The following is a description of a gene set: Human Gene Set: MODULE_23 studied in species Homo sapiens Liver genes - metabolism and xenobiotics., and this is the list of marker genes: FZR1, PAX3, HMGCS2, CITED2, CPB2, CYB5A, PLG, ARHGDIG, SCO2, ITIH2, AQP3, SLC13A2, SMAGP, SOD3, CYP2B6, NOVA1, PROC, KCND3, POLD2 (DNA polymerase delta 2, accessory subunit), ECI1, ROR2, PCK2 (NCBI Gene Id 5106), C2, CNKSR1, ODF1, SNCG, ALAS2, CFHR3 (complement factor H related 3), AKR1C3 (aldo-keto reductase family 1 member C3), SLC22A18AS, HCN3, DOK1, MMP11, NFKBIB, AKR7A3, SERPINA4, MTHFR, VGF, SELENOP, TBX19, DPT, PTCH1, CD14, TNFRSF10B, LGMN, CFAP410, GRK1, CYP2A7, HAP1, UBE2L6, IGFBP2 (insulin like growth factor binding protein 2), PLCG2, C6, CLEC10A, APCS, IGF1, SLC7A11, ITIH3, AADAC (NCBI Gene Id 13), LRP1, IGFBP1, MAOA, PCBD1, PHYH, ASGR1, XDH, ARID1A, SFTPC, INHBC, FBP1, CYP4F3, VSIG4, ARSA, C4BPA, MAP2K3 (mitogen-activated protein kinase kinase 3), CHRNB1, ABLIM3, AGPAT2, E2F1, GPX3, AQP5, SPRR2C, ARC, RHBDL1, TIMP3, HPD, CDC42EP1, FGA, SRPX, HTR2A, CYP2C8, CYP2D6, ITIH4 (inter-alpha-trypsin inhibitor heavy chain 4), QSOX1, HGD, FURIN, TCIRG1, PRELID3A (NCBI Gene Id 10650), TRIM16, VAMP5 (NCBI Gene Id 200553), TNFRSF14, APOB, COL18A1, DNASE1L3, GPLD1, NTNG1, ACOX1, DDC, FGR, DAO, CHPF, ALDH1B1, RHOB, AKR1C1, CYP2A6, DOLK, AGXT, ENPP1, MGP, TYR, DKK4, ACOX2 (NCBI Gene Id 8309), GJB1, FLOT1, EFNA2, GYPB, SLC38A10, FN1, VSNL1, HP, ATF5, GATM, CPN2, MEF2C (myocyte enhancer factor 2C), FUCA1, PCYT2 (NCBI Gene Id 5833), DDT, RPS26, MUC1, SORBS2, F2, FGL1, NR0B2, MEN1, RBP1 (retinol binding protein 1), ALDH1L1, STAT2, MTHFS, PEPD, EGFR, BCL2, FETUB, VEGFA, ATP4A, TGFB1, CD3E, IL4R, ERBB3, SYNPO2L, CES1, TBXT, HPR, IKBKG, IFI27, CELSR3, ITGA5 (integrin subunit alpha 5), LCAT, CTSF, ATP11A, CFHR1, ARHGEF16, PBX1, RAMP2, F7, SLC10A1, GNE, FCN2, ILRUN, ASIC2, LAIR1, TBX5, C4BPB, CYP4B1, HMGCL, APEX2, EIF4EBP1, ALPL, EXD2, NUPR1, NHERF1, PLAAT4, APOM (NCBI Gene Id 55937), CLEC3B, CYP2C9, SLC22A18, RBMS3, ELN, PTGDS, ETFB, MAOB, LAMB2, SERPIND1, COL6A1, IL32, SAC3D1, GSTZ1, HTR3A, DNAH3, OGG1, BMP1, SLC6A2, TBL3, TM4SF4, ADIRF, DNM1, RUNX1T1, REN, FUT1, ADH1B, LBP, NR1D1, SLC5A2, KRT31, DLX4, MAPKAPK3, UGT2B4, IGHM, PAH, LTBR, AHSG (NCBI Gene Id 780898), AK4, IGFBP3, ACAA1, MYL9, GPT, SERPINC1, ALDH3A2, RGN, APOC2, CFB, NPFF, LLGL2, AMT, AMELX (amelogenin X-linked), DHRS1, ALAS1, QDPR, G0S2, NFKBIL1, BCKDK, GMPR, COL2A1, COX6A2, TAF1, ICAM3, ACSL1, ALDH7A1, TRPM2, MAT1A, APOL1, CFP, PFKFB2, APOA1, ARG1, F10, FHIT, ORM2, GLYAT, ITGB5, C1S, PLIN2, CD22, CADM1, IL7R, GAGE12F, APOC1, COL1A1, TM7SF2, CYP4A11, TRIB1, SEMA6C, TTLL12, PROCR (protein C receptor), NAT8, DEFB1, KLKB1, TMEM63A, CYP27A1, TLE1, ENTPD2, TIMM17B, HTR4, TFAP2B, H2BC12, APRT, KRT86, CFH, POU4F1, SEZ6L, DNASE1, CP, STMN1, FABP1, STOML1, RBP4, CYP2E1, MME, HSPB2, TGM2, FGFR4, CST7, CYB5R1, JAK3, SMTN, CCS, RAC3, CD34, SHBG, TNXB, APOC3, HSD17B6, PPP1R1A (protein phosphatase 1 regulatory inhibitor subunit 1A), PON3, PDGFRA, RIBC2, CLN3, APOE, IGF2, ATP10B, NME3, BCKDHA, SLC37A4, FADS1, ALDH1A1, TFR2, EFNA1, MAL, PPP6R2, FXYD1, FGB, WAS, TIMP2, ACR, H3C6, AOX1, HSPG2, COL7A1, FCGRT, SBNO2, PLK3, GSTM1, CDK6, BRD4, ACACB, ABCC3, F12, EPHX2, ATP2B4, BDH1, PCDH1, CLDN5, TDO2, IGFBP4, GRB7, HPN, PAX7, ALB (NCBI Gene Id 29004), ACO1 (NCBI Gene Id 48), SELE, NRG2, SDC1, TGFBI, SLC43A1, UCN, VTN, TRAPPC6A, AZGP1, ZKSCAN7, EPAS1, RGS10, SLCO2B1, GCGR, RNASE4, ALDH6A1, GSTA2, UGT2B15, NEURL1, ST3GAL4, ENG, CCL15, HAAO, MAN2B1, KCNQ3, PROX1, FOLR1, ELAC2, SLC22A1, UGT2B7, CYP3A4, TULP1 (TUB like protein 1), CCL2, AGTR1, RGS4, ANPEP, CALML3, STX1A, SHMT1, STARD5, HYAL1, HTR7, CDH1, AQP7, AANAT, LGALS4, ST6GALNAC4, AEBP1, IHH (NCBI Gene Id 50819), LY6G6C, UGDH (NCBI Gene Id 7358), TNF, KRT18, DHRS3, NECTIN2, S1PR4, SEMA4D, SERPINA5, SERPINA6, AQP9, GTPBP1, ITGA10, TFF2, PC, RXRA, CBS, TNFRSF1B, GREM1, CD8B, FMO4, GADD45B, GNMT, SMPDL3B, SCD, ADH1C, CLDN3, AVPR1B, SORD, SERPINF2, N4BP2L1, CYP2C19, BLVRB, DPYSL4, ASGR2, TRIM29, SLPI, FDXR, HSD11B1, TCF7, ISG15, SCAMP5, MPG, PCOLCE, SPP2, RHOD, SLC6A11 (NCBI Gene Id 6538), KRT4, ANXA9, PRSS8, HPGD, SERPINE1, RIDA, CPN1, PMVK, C1QB, MGLL, AR, PAEP, AGT, CYP4F12, SERPINA3, DIO1, ECM1, SLC25A1 (solute carrier family 25 member 1), FMO5, SERPINA1, TM4SF5, ECHS1, MTHFD1, ALDOB, C8A, ALDH4A1, LRP3, FADS2, APOC4, CRYBA4, ITIH1, HRG, BHMT, APOH, CASP2, IL3, GYPE, PLAT, CDK5R1, SLIT2, FEV, MST1, GCHFR, PCK1, IFIT1, GCKR, FBXL7, CD151, TMEM97, CYP2J2, IVD, CDA, LTC4S, SCP2, BSN, ACOT2, GLRX, MT1G, SRPK3, ITGBL1, HOMER2, ADH1A, AMBP, TRPC4AP, GC (NCBI Gene Id 2638), RNF167, ESR1, NRTN, NKG7 (NCBI Gene Id 4818), SLC2A1, GOT1, HMOX2, FMO3, CDH16, EFS, RARRES2, IGHG3, NNMT, NAAA, KNG1, SDS, ABCC6 (NCBI Gene Id 5823), LECT2, HLA-DMA, CLDN9, PRF1, SLC11A1, DCHS1, DLEC1 (NCBI Gene Id 9940), C8B, ST6GAL1, CPS1, STAB1, CCND1, TNFRSF25, EPHX1, NTSR2, FAM107A, PSD4